Given this list of marker genes NRAS, ANKRD1 (ankyrin repeat domain 1), POLR2M, IRX3, CXXC5, FHL1, CALCRL, RBPMS, here is a description of the gene set: Human Gene Set: CASTELLANO_HRAS_AND_NRAS_TARGETS_DN Genes down-regulated in MEF cells (embryonic fibroblasts) isolated from HRAS and NRAS double knockout mice. studied in species Mus musculus from publication Castellano E, De Las Rivas J, Guerrero C, Santos E (PMID 16909116) We characterized differential gene expression profiles of fibroblast cell lines harboring single or double-homozygous null mutations in H-ras and N-ras. Whereas the expression level of the individual H-, N- and K-ras genes appeared unaffected by the presence or absence of the other ras loci, significant differences were observed between the expression profiles of cells missing N-ras and/or H-ras. Absence of N-ras produced much stronger effects than absence of H-ras over the profile of the cellular transcriptome. N-ras(-/-) and H-ras(-/-) fibroblasts displayed rather antagonistic expression profiles and the transcriptome of H-ras(-/-) cells was significantly closer to that of wild-type fibroblasts than to that of N-ras(-/-) cells. Classifying all differentially expressed genes into functional categories suggested specific roles for H-Ras and N-Ras. It was particularly striking in N-ras(-/-) cells the upregulation of a remarkable number of immunity-related genes, as well as of several loci involved in apoptosis. Reverse-phase protein array assays demonstrated in the same N-ras(-/-) cells the overexpression and nuclear migration of tyrosine phosphorylated signal transducer and activator of transcription 1 (Stat1) which was concomitant with transcriptional activation mediated by interferon-stimulated response elements. Significantly enhanced numbers of apoptotic cells were also detected in cultures of N-ras(-/-) cells. Our data support the notion that different Ras isoforms play functionally distinct cellular roles and indicate that N-Ras is significantly involved in immune modulation/host defense and apoptotic responses.